The following is a description of a gene set: species: Homo sapiens Human Gene Set: GSE21379_WT_VS_SAP_KO_CD4_TCELL_UP Genes up-regulated in CD4 non-follicular helper T cells: wildtype versus SH2D1A knockout. from publication Yusuf I, Kageyama R, Monticelli L, Johnston RJ, Ditoro D, Hansen K, Barnett B, Crotty S (PMID 20525889) CD4 T cell help is critical for both the generation and maintenance of germinal centers, and T follicular helper (TFH) cells are the CD4 T cell subset required for this process. SAP (SH2D1A) expression in CD4 T cells is essential for germinal center development. However, SAP-deficient mice have only a moderate defect in TFH differentiation as defined by common TFH surface markers. CXCR5+ TFH cells are found within the germinal center as well as along the boundary regions of T/B cell zones. Here we show that germinal center associated T cells (GC TFH) can be identified by their co-expression of CXCR5 and the GL7 epitope, allowing for phenotypic and functional analysis of TFH and GC TFH populations. Here we show GC TFH are a functionally discrete subset of further polarized TFH cells, with enhanced B cell help capacity and a specialized ability to produce IL-4 in a TH2-independent manner. Strikingly, SAP-deficient mice have an absence of the GC TFH subset and SAP- TFH are defective in IL-4 and IL-21 production. We further demonstrate that SLAM (Slamf1, CD150), a surface receptor that utilizes SAP signaling, is specifically required for IL-4 production by GC TFH. GC TFH cells require IL-4 and IL-21 production for optimal help to B cells. These data illustrate complexities of SAP-dependent SLAM family receptor signaling, revealing a prominent role for SLAM receptor ligation in IL-4 production by germinal center CD4 T cells but not in TFH and GC TFH differentiation., and this is the list of marker genes: ADGRA2, DLK1, SMPDL3B, DGAT2, LITAF, TMEM132A, KHK, MYLK, TGM1, SSX2IP (NCBI Gene Id 22892), RHOJ, SH3D19, UBASH3A, PROM1, RPS16, PTPN12, TGFBI, ANO8, GMDS, HIRIP3, PLIN5, STIP1 (stress induced phosphoprotein 1), FRK, PTGS1, ARPIN, SRPK3, TRMT6, CARD10, APP, FJX1, AJUBA, S1PR3, IRF4, TMC4 (NCBI Gene Id 147798), CC2D2A, STK16, NRARP, GLS2, EXOC3L1, KDM2B, CLEC11A, NSMCE1, ZDHHC16, ASS1, GTF2H2, DDX56, MRPS25, NAA20, TYMS, KNSTRN, XPNPEP1, DRAM1, TNFAIP8L1, NPRL2, STAP2, XDH, KNOP1, GJB2, DENND2C, ZNF334, PTTG1IP, DOCK6, ATG101, RALB, ROM1, PRNP, ASCC1, CD38, BNIPL, FAM181B, SLC44A1, PRXL2C, ARTN, SERPINH1, ACP5, COL18A1, CCNYL1, SEM1, REV1, CYB5B, NPY5R, AVEN, ZC3HC1, TTC39A, LGALS9B, RIN1, GFOD2, THTPA, RAB29, PRIM2 (DNA primase subunit 2), CTDSPL, BCL2L13, CSRP2, PALLD, SNF8, ANGPTL2, TULP1, FAH, MIPEP, GSTM1, RASGEF1B, RAD52 (NCBI Gene Id 5893), SOX18 (SRY-box transcription factor 18), SLC31A1, MYO1E, CD9, RND2, GCHFR, PIMREG, MAGED2, TTC23, TMEM204, FGF3, RAD51B, NMNAT3, SOAT2, NRTN, MEG3, MCF2L, CRIP2, CCNB1IP1, PIP5K1B, ITGB1BP1, CRELD2, ZCCHC3, GDE1, GLT6D1, RAPH1, CLU, H19, PHLPP1 (NCBI Gene Id 23239), HMCES, NRP2, CDK5RAP2, SPATS2, OSTF1, RAB11A, PLOD3, TMC8, NREP, SSTR5 (NCBI Gene Id 6755), LTA, HSPA8, PPFIA3, SLC26A6, TEAD2, ITGA6 (NCBI Gene Id 3655), CMTM3, SLC7A8, ITGB3, MRPS2, GPR179, C11orf52, FAM118B, TFPI, ATG9B, CAVIN1, EXOC3L4, KLHL23, TMEM215, FOXJ1, RNASE4, GORASP2, CYB561, CRELD1, DBNL, BEX4, ABCF2, NKX2-5, CELF5, HOMER1, ICAM2, GPX8, DHRS3, SPIN4, AKAP14, SEBOX, CDH5, CCND3, NOS3, IL17RC, COBL, SKA1, FUOM, NRP1, LUZP1, TP53INP2 (NCBI Gene Id 58476), ACOT7, THY1, CD320, PSMA8 (proteasome 20S subunit alpha 8), FHOD1, TANC1, MEF2C, ATMIN, MYOM1, FAM50A, GPD1L, MYL11, CHADL